The following is a description of a gene set: Immune cell-specific expression is one indication of the importance of a gene's role in the immune response. In order to identify such patterns, we set out to broadly profile gene expression in a variety of immune cells. Genes down-regulated in comparison of naive CD4 T cells versus stimulated CD4 Th2 cells at 48 h. from publication Abbas AR, Baldwin D, Ma Y, Ouyang W, Gurney A, Martin F, Fong S, van Lookeren Campagne M, Godowski P, Williams PM, Chan AC, Clark HF (PMID 15789058) species: Homo sapiens Human Gene Set: GSE22886_NAIVE_CD4_TCELL_VS_48H_ACT_TH2_DN, and this is the list of marker genes: RNF170, SNX1 (sorting nexin 1), PDCD6, PSMC2, ACTG1, MED18, ZBTB24, STAU2, SMCO4, TARDBP, H2AX, TFRC, NUP153, TBC1D10B, SUPT16H, PSMD1, NUP133, GFI1, ARL6IP1, AP5S1, PPP2R3C, INVS, CALM2, PIGF, OGFOD1, KNTC1, SLC25A12, CDC123, PLAGL1, SEPTIN8, COPG1, EED, PPP1R8, TNFSF10, RBL1, SMC6, WDR7, PSMG2, DDB2, FADS2, COA3, APTX, DSN1, CLTC, SLC25A44, PSEN1 (presenilin 1), ZFYVE21, DHDDS, RNF34, LBHD1, CCNF, FANCI, IDH1, FRMD4B, KIF3A, SMC4, GALNT3, H2BC8, PDSS2, BATF, PHTF1, TMEM33, TTLL7, GAPDH, CRIPT, POLR2B, DIABLO, IMMT, AGO2, ALAS1, TPI1, BARD1, PSMD5, LDLR, MSMO1, DCPS, ZMPSTE24 (zinc metallopeptidase STE24), SDC4, HSPA13, GPR19, EIF4G1, BAZ1B, CEP76, PSRC1, AASDHPPT, ACOT13, ENO1, IL4, ITPR1, MIS18A, ZNF180, TOP2A, MLEC, LARP4, OXSR1, APOBEC3B, PIGB, YWHAE, OXSM, GLO1 (glyoxalase I), HEXB, MRE11, MT1H, COPB1, KCTD5, PARK7, H2BC5, CCDC86, NDUFC2, ZCCHC8, ATP6V1A, WEE1, RRM2, GABPB1, CPOX (coproporphyrinogen oxidase), TMED2 (transmembrane p24 trafficking protein 2), UNC50, TNFAIP1, KCNK1, BAG2, TRIP12, PIP5K1B, COPB2, CDC20, TAP1, PKM, DYNLL1, CKLF, MCMBP (minichromosome maintenance complex binding protein), NDUFAF1, DNAJB4, SEC61B, MAD2L1BP, PRC1, MTHFD2, GDE1, GK3, MED21, TM9SF1, CCDC51, CDC7, CANX, MPV17, VPS54, DYNC1I2, REEP5, NDUFB3, MT1E, ALG5, ATP2A2, HJURP, ACAA2, CCR1, HMGB2, HINT1, CENPQ, PARP1, TIMM8B, DARS1, MIF, SLC1A4, PSMA5, MINPP1, MT1F, ESPL1 (extra spindle pole bodies like 1, separase), KIFBP (kinesin family binding protein), PGAM1, MT1G (metallothionein 1G), STARD7 (NCBI Gene Id 56910), PPP4C, RRAS2, TOR1AIP1, ETNK1, RDH11, NEDD8, THYN1, CCNB2, SNX5, TYMS, MCM3, MGAT2, MYL6B, CASP3, H2BC12L, STAMBP, NAT1, MRPL35, ELAVL1, CAMK1, PCNA, RAD51C, COX17, RRM1, ACTR2, HPS5, NEK7, TMCO1, NOP10, MT1HL1, FADS1